The following is a description of a gene set: species: Mus musculus Mouse Gene Set: GOBP_FEMALE_MEIOSIS_CHROMOSOME_SEGREGATION The cell cycle process in which genetic material, in the form of chromosomes, is organized and then physically separated and apportioned to two or more sets during the meiotic cell cycle in a female., and this is the list of marker genes: Ttk, Top2a, Ncaph, Meikin, Mlh1, Sycp3, Ncaph2 (NCBI Gene Id 72506), Plk1